The following is a description of a gene set: Purpura that is flat (non-palpable, not raised). species: Homo sapiens Macular purpura Human Gene Set: HP_MACULAR_PURPURA, and this is the list of marker genes: LYZ, RUNX1, SAMD9, PML, USP8, WAS, F13A1, ITGA2, COL5A1, CD109, OCLN, USP18, TREX1, STAT3, GFI1B, APOE, CLCN7, GATA1, GNA14 (G protein subunit alpha 14), JAK2, PTPRJ, ETV6, HOXA11, FYB1, PRKAR1A, WIPF1, NR3C1, STAT5B, DPP9, CALR, AIP, TBXA2R, RARA, TP53, RAB27A, CHST14, NAGA, NABP1, FUCA1 (NCBI Gene Id 2517), COL1A1, FIP1L1, LCP2, IRF2BP2 (NCBI Gene Id 359948), ITGB3, DCLRE1B, GP9, F9, COL3A1, GIMAP5, F13B, FERMT3, GP1BA, TET2, FCGR2C, MPL, HPS6, PEPD, NPM1, STXBP2 (NCBI Gene Id 6813), UNC13D (NCBI Gene Id 201294), CDH23, GNE, F8, PLCG1, GP1BB, NEU1, ITGA2B, ZBTB16, USP48, NUMA1, PRF1, SBDS, GBA1, P2RY12, ETHE1, TERT, BCOR (BCL6 corepressor), F2, IFNG, TERC, CASP10, GP6, HCK (NCBI Gene Id 3055), ATRX, TBL1XR1, HPS1, COL5A2, BRAF, GGCX, STX11